The following is a description of a gene set: species: Mus musculus The chemical reactions and pathways involving quinolinate, the anion of quinolinic acid, also known as 2,3-pyridinedicarboxylic acid. Mouse Gene Set: GOBP_QUINOLINATE_METABOLIC_PROCESS, and this is the list of marker genes: Bcl10 (NCBI Gene Id 99555), Kmo, Bin1, Kynu, E2f1, Rac1, Xiap, Htt, Extl3, Acmsd, Haao, Qprt, Ido1, Reg3g